Given this list of marker genes Fosl2, Rb1, Pdcd4, Tsku, Parp1, Trp53inp1, here is a description of the gene set: species: Mus musculus Any process that modulates the frequency, rate or extent of myofibroblast differentiation. Mouse Gene Set: GOBP_REGULATION_OF_MYOFIBROBLAST_DIFFERENTIATION